Given this list of marker genes WLS, CELA1, SRP54, IGF1, XBP1, PDX1, PTF1A, INSR, IGF2, NR5A2, here is a description of the gene set: studied in species Homo sapiens Human Gene Set: GOBP_EXOCRINE_PANCREAS_DEVELOPMENT The process whose specific outcome is the progression of the exocrine pancreas over time, from its formation to the mature structure. The exocrine pancreas produces and store zymogens of digestive enzymes, such as chymotrypsinogen and trypsinogen in the acinar cells.